Given this list of marker genes Fancb, Nfix, Nfatc1 (nuclear factor of activated T cells, cytoplasmic, calcineurin dependent 1), Nanos2, Dek, Cdk6, Lin37, Nfia, Mir489, Nfib, here is a description of the gene set: studied in species Mus musculus Mouse Gene Set: GOBP_CELL_QUIESCENCE A specialized resting state that cells enter in response to cues from the cell's environment. Quiescence is characterized by the absence of cell growth and division, by a reprogramming of global gene expression, and by changes characteristic of the organism and specific cell type. Depending on external conditions, quiescence may persist until cell death or cells may resume cell growth and division. In some cell types or under certain conditions, cellular metabolism may proceed.